Given this list of marker genes ACTB, HSP90AA1, ATP2B4, NOS1AP, DYNLL1, CALM3, CAV1, HSP90AB1 (NCBI Gene Id 3326), AKT1, ESR1, here is a description of the gene set: Human Gene Set: GOMF_NITRIC_OXIDE_SYNTHASE_REGULATOR_ACTIVITY studied in species Homo sapiens Binds to and modulates the activity of nitric oxide synthase.